The following is a description of a gene set: Human Gene Set: WP_CHOLESTEROL_BIOSYNTHESIS_WITH_SKELETAL_DYSPLASIAS studied in species Homo sapiens Cholesterol biosynthesis with skeletal dysplasias, and this is the list of marker genes: EBP, NSDHL, DHCR7, CYP51A1, DHCR24, SC5D, LBR